The following is a description of a gene set: from publication Gavish A, Tyler M, Greenwald AC, Hoefflin R, Simkin D, Tschernichovsky R, Galili Darnell N, Somech E, Barbolin C, Antman T, Kovarsky D, Barrett T, Gonzalez Castro LN, Halder D, Chanoch-Myers R, Laffy J, Mints M, Wider A, Tal R, Spitzer A, Hara T, Raitses-Gurevich M, Stossel C, Golan T, Tirosh A, Suvà ML, Puram SV, Tirosh I (PMID 37258682) Human Gene Set: GAVISH_3CA_METAPROGRAM_EPITHELIAL_V_ATPASE In this study, an extensive analysis was conducted to define meta-programs (MPs) capturing intra-tumor heterogeneity across a spectrum of tumor types. The approach utilized non-negative matrix factorization (NMF) to analyze each cell type separately within individual tumor samples. This involved the analysis of malignant cells, macrophages, fibroblasts, endothelial cells, epithelial cells, T-cells, and B-cells. NMF was executed with varying parameter values (K=4, 5, 6, 7, 8, 9), thereby generating 39 programs for each cell type per sample. Each NMF program was summarized by the top genes based on NMF coefficients.\nRobust MPs were then delineated for each cell type using a set of stringent criteria, including recurrence within the same tumor, similarity to programs in other tumors, and non-redundancy within a tumor. Subsequently, these robust NMF programs were clustered (per cell type) based on Jaccard similarity, leading to the identification of MPs associated with each cell type.\nTo enhance the quality of the MPs, a refinement steps were undertaken, involving the removal of MPs suspected of reflecting low-quality data (with an overrepresentation of ribosomal proteins or mitochondrial-encoded genes), single-study inclusion, or similarity to miss-annotated cell types. Genes upregulated in subsets of cells of a given type within various tumors species: Homo sapiens, and this is the list of marker genes: FAM24B, HLA-B (NCBI Gene Id 730410), MT-ND3, IGFBP7, CA12, TMEM213, ITGA6, CLCNKA, EPS8, RTN4, CA2, SLC26A7 (NCBI Gene Id 65015), LGALS3, BSG, LITAF, SMIM6, DSG2, SLC25A39, ATP6V0A4, HLA-C, RCAN2, C12orf75, ATP6V0D2, MALAT1, MAL, LINC01187, IGFBP5, PTGER3 (prostaglandin E receptor 3), TMSB4X, RHCG, ATP6AP2, ATP6V1A, PLAAT4, CLCNKB, CLNK, CTSD, TFCP2L1, ATP6V1C2, DHRS7, IL18, SCIN, CD9, ATP6V0B, EPCAM, ATP6V1G3, ADGRF5, HEPACAM2, ARHGAP18, ATP6V1B1, SMIM24